The following is a description of a gene set: Any process that results in a change in state or activity of a cell or an organism (in terms of movement, secretion, enzyme production, gene expression, etc.) as a result of an arsenic stimulus from compounds containing arsenic, including arsenates, arsenites, and arsenides. Mouse Gene Set: GOBP_RESPONSE_TO_ARSENIC_CONTAINING_SUBSTANCE studied in species Mus musculus, and this is the list of marker genes: Cdkn1a, Ppif, Vcp, Gsto1, Alad, Ugt1a1, D1Pas1, Nr3c1, Serpinf1, Nefh, Mapk13, Fech, Rnf4, Zc3h12a (zinc finger CCCH type containing 12A), Gsto2, Hsf1, Gria1, Zfand2a, Slc4a1, Tnfrsf11b, Slc38a2, Cyp1b1, Ddx3x, Zfand1, Rbm4, Gclc, Hmox1, Dhx36, Daxx, Aqp9, Lonrf2, Mknk2, Hnrnpa1, Uros, As3mt, Atg7, Cyp1a1, Nefl